The following is a description of a gene set: species: Mus musculus Mouse Gene Set: GOBP_NEGATIVE_REGULATION_OF_CELL_FATE_COMMITMENT Any process that stops, prevents or reduces the frequency or rate of cell fate commitment. Cell fate commitment is the commitment of cells to specific cell fates and their capacity to differentiate into particular kinds of cells. Positional information is established through protein signals that emanate from a localized source within a cell (the initial one-cell zygote) or within a developmental field., and this is the list of marker genes: Nanog, Mesp1, Tnfsf18, Glis1, Dkk1, Sfrp2, Casz1, Hes1, Gfi1, Loxl3 (NCBI Gene Id 16950), Spdef, Sostdc1, Nkx6-2, Cd69, Lgals1, Fzd7, Tbx21 (T-box 21)